Given this list of marker genes RAD51B, KCNJ9, RIMKLB, SAV1, HMBOX1, PRDM16, MBNL1, JAKMIP3, MTMR4, LTO1, CABP7, HPCAL4, RAB38, CTTNBP2NL, ZDHHC22, PDS5A, INO80, USF2, ADTRP, LRP8, TLR2, FIBIN (NCBI Gene Id 387758), EYA3, LPL, ENTPD1, ZNF174, ELAVL3, CPED1, CPXM2, AHDC1, PLA2G7, UNC5B, MC2R, PRDM10, LUZP1, WIPI1, PURA, HEY2, FMR1, GYPC, RWDD1, ZFP1, ISL2, NTM, LRRC2, EEIG2, PPFIA1, FOXK1, NAV1, KCNIP1, ZNF706, PCNP, OSBP, IRX5, OAS3, PIK3R5, PAX3, NOS1, ZNF608, BNC2, ZNF557, CCL16, RIMS4 (NCBI Gene Id 200225), SETBP1, STARD7 (StAR related lipid transfer domain containing 7), AMMECR1, CPLX2, HACD4, CCDC93 (coiled-coil domain containing 93), CBS, UPK3BL1, TGFBR3, SBNO1, DLX6, RIN2, LYSMD3, SHOX, NHERF2, C12orf50, PLA1A, CALN1, ZNRF3, POU3F3, EPHA10 (NCBI Gene Id 440580), PAGR1, TNS1, DIAPH1, FAM131B (family with sequence similarity 131 member B), IL5RA, OSBPL8, PTPRB, PROSER2 (NCBI Gene Id 254427), KMT5B, TREML4, TMCO1, ZSWIM6, PPP1R12B, CFAP97D1, BHLHE22, PTPRN2, CABP5, TMEM52, TPPP, RPS27L, ZNF280B, NELL1, RDX, MRAP2, SLC33A1, EGFR, MTURN, CD86, CD3E, TGFB2, FEN1, CCDC103, ZBTB20, NRN1 (neuritin 1), SKA2, SOX5 (SRY-box transcription factor 5), QRSL1, KCNA4, INHBB, CCND1, CALHM5, KIAA1549L, ACTR3C, HS3ST5, TMEM178B, DIRAS2, ZNF211, SIGLEC15, MTO1, SH3PXD2A, ZNF432, LENG8, PDE7B, PRKCE, TRIM66, NIPA1, CORO2A, GDF11, KRT26, JRKL, ZNF431, EMP1, RNF213, ZDHHC9, DIRAS1, ACSM2A, ZFHX2, DPF3, SLC5A12, PFKFB3, OAS1, ZNF239, OGA, DCAF12L2, BRINP2 (BMP/retinoic acid inducible neural specific 2), MDM2, UBE2R2, DLG2, KCNK17, DLST, MEPCE, FREM2, COQ3, TMEM200B, MAP3K2, DCUN1D5, FRMD3, PCM1, KIAA1328, CEP126, CELF4, RTTN, WDR33, DPYD, GPR176, RAB8A, THRA, DISC1, SLC4A8, ARL15, SETX, ACER3, WDR77, TMCC1, B4GALT5, EGFLAM, SHTN1, OTUB2, CNTD1, CACNG8, SLC41A2, SLAIN2, SLC25A43, ID4, MPZ, PAPPA, CC2D2B, MYORG, BBX, RAPH1, ANKS4B, POU3F2, RREB1, TMEFF2, CCDC77, PHF21A, CLCC1, C22orf46P, REP15, LHFPL3, ST6GAL1, PARD3B, PAK3, ELAVL4, ZNF514, SOST, CDC42BPA, HRH1, SPATA18, EPHA4, IQSEC3, KLHL29, GLCE (glucuronic acid epimerase), HSPG2, NAA30, ATG10, HBS1L, SLC7A14, CPD (NCBI Gene Id 1362), METTL8, LRRC10B, ENSG00000274276, CALU, CD300E, FRMPD4, QSOX2, NFKBIE, SHFL, ERCC1, PROM1, MPPED2, ADPRH, TRAK1, ZNF354A (zinc finger protein 354A), EPB41L3, AGAP1, RORA, PDGFA, DUSP7, ENPP1, HDAC3, GPATCH11, ZNF367, CPLX3, ZNF624, MYOG, TMEM245, TVP23C (trans-golgi network vesicle protein 23 homolog C), ZNF609, FFAR4, TMEM196, PPP6R1, KIF1C, TBL1XR1, LSAMP, VPS18, PLA2G4E, AP4S1, FAM199X, BCL11A, PRMT6, DDX19A (DEAD-box helicase 19A), NEIL2, INO80D, GDAP1L1, ZBTB7A, CNOT9, LPP, PITX2 (NCBI Gene Id 5308), PITPNM3, AICDA, THAP6, CLCN3, SLC30A9, PPP4R1, STK17A, POU2F2, GPR179, AP3D1, SEPTIN8, ADAMTS17, LACC1, SNX20, FCRL4, GLS2, VOPP1 (VOPP1 WW domain binding protein), SLC22A1, SEMA3A, MBNL3, NOTCH2, SMG7, CASK, WSCD2, F7, RBM20, PPARGC1B, CHMP7, CKAP2L (cytoskeleton associated protein 2 like), KRBOX4, WBP1L, MSI2, NEURL1B, PPP3CA (NCBI Gene Id 5530), FEM1A, PEA15, SPON1, PLA2G2F, APOLD1, SMTNL2 (NCBI Gene Id 342527), GRAMD1B, PLCL1, STK17B, SIPA1L3, FBXL16, GPATCH2L, ACTN2, SOCS6, KCNK6, GPBP1L1, DLG4, ESRRG, SMARCA4, PRDM2, TGFA, TTF1, CELSR2, OSBPL10, SEL1L3, THSD7A, RFT1, FAF2, ASAH2B, EMX2, USH2A, LGSN, NUP205, KAZALD1, TSPOAP1, AGPAT1, TLN2, STAT5A, PLEKHA6, CASP2, RAPGEF3, ZNF880, CUX1, MID1, ARHGAP19, RIMBP2, ELOVL7 (ELOVL fatty acid elongase 7), TMEM135, SCN7A, TNFRSF13B, TBX5, PLXNA4, INMT, OLIG3, GOLGA7, CLIP4, JADE2, ZDHHC21, RANBP3L, SHOX2, SNRK, GRID1, C2orf49, PRDM11, CDV3, ATP6AP1L, ZZZ3, PLXNA1, DGKE, LRIG3, CHST15, HIF1AN, GK5, TRMT12, ZNF543, EIF1AD (NCBI Gene Id 84285), OCRL, NBEAL1, ZNF23, RAB11FIP2, MYEF2, ANK1, PCGF3, MAP1B, SOX2, GXYLT1, here is a description of the gene set: species: Homo sapiens from publication Chen Y, Wang X (PMID 31504780) Genes predicted to be targets of miRBase v22 microRNA hsa-miR-7110-3p in miRDB v6.0 with MirTarget v4 prediction scores > 80 (high confidence targets). Human Gene Set: MIR7110_3P